Given this list of marker genes Myh11, Eef2k, Tmod1, Ttn, Rap1gds1, Mybpc3, Dapk3, Tcap, Actr3, here is a description of the gene set: A process that is carried out at the cellular level which results in the assembly, arrangement of constituent parts, or disassembly of a filament composed of myosin molecules. species: Mus musculus Mouse Gene Set: GOBP_MYOSIN_FILAMENT_ORGANIZATION